Given this list of marker genes NFIB, G6PC3, ZFP62 (NCBI Gene Id 92379), TSPAN13, NECTIN4, TP53BP1, ENO3, FGD3, FAAP24, SCAMP2, ZNF658, FZD8, NIPA1, HDAC11, RAB2B, CRHBP, MED31, MRC2, PNPLA2, FRS3, RNF135, ENG, NCS1, MAP3K12, SERPINB9, AGPAT2, PDE4DIP, WDR75, AJUBA, MUL1, SPINDOC, SCNN1B, GLT8D2, EVL, SFTPC, POSTN, PPFIA4, PIGP, SERINC3, SSBP4, IRF2BPL, IRF3, BTG3, UBALD1, METTL22, CCDC122, DENND6B, TMEM144, PIP4K2C, MYBPC3, GCNT1, CALML4, SMPD1, CLPP (caseinolytic mitochondrial matrix peptidase proteolytic subunit), TP53I11, CAMTA2, FUBP3, GKAP1 (G kinase anchoring protein 1), MMS19, EPAS1, CLPTM1, JUP, SCN1B, RLIM, TBC1D9, SLC23A2, FAM234B, PPP1R10 (protein phosphatase 1 regulatory subunit 10), MYRIP, NT5C3B, LAMP2, NDFIP2, MARCHF2, AUP1, SOAT2, MNT (MAX network transcriptional repressor), ENC1, KLHL25, ABHD14A, METTL18, MOB2, TICAM1, PAPSS1, NOXO1, HEXD, KCP, SESN1, HS6ST1, CMYA5, TM2D1, ZNF141, ZEB1, SLC36A2, ARHGEF40, BANK1, DAGLB, ELAVL4, TTYH1, CEP68, NMD3, ZNF862, MYO7A, GBA1, RWDD3, CNNM2, TNFRSF11A, PLAAT3, NAA80, GNPTG (N-acetylglucosamine-1-phosphate transferase subunit gamma), ZNF32, HMOX2, ALDH7A1, ZNF777, TXNRD3, EXOG, RS1, GADL1, ZFYVE1, LONRF3, CNP, HERC2, SUSD3, ACTL7A, MYMK (myomaker, myoblast fusion factor), XPO5, FLRT1, PPM1E, COMMD9, CNPY3, OAF, TMED5, PLEKHO1 (pleckstrin homology domain containing O1), C19orf44, ITPKB, CAND2, DYNLT3, PRAF2, SH2B2, ATP6V0C, TMBIM1, PTBP1, C1orf122, CD22, TTC39B, IQSEC2, ITGB3BP, IDUA, PORCN (porcupine O-acyltransferase), C4B, PECR, ZNF354C, SETD2, SGSM3, VIPR1, EPS8L1, DNMBP, NDRG2 (NCBI Gene Id 57447), VWF, TGIF1, ZNF35 (NCBI Gene Id 7584), SLC25A23, IFT172, LAP3, NFKBIB, LTF, MYO1E, SRGAP3, GLB1, ZFP37, PIP4P1, GLMP, ADGRL2, CDK20, SSTR5, GLT8D1, TMEM50A, P2RX7, EEFSEC, EMC3, TEX35, GSTM3, HGH1, TPRKB, TJP2, B4GALT3, WBP2, CCT3, PPM1F, PDF, COMP, VAT1L, SMIM1, TMED4, PTPMT1, C11orf54, UBE2I, CEP85, CXCL16, KIF21B, DDA1, here is a description of the gene set: from publication Kerkar SP, Goldszmid RS, Muranski P, Chinnasamy D, Yu Z, Reger RN, Leonardi AJ, Morgan RA, Wang E, Marincola FM, Trinchieri G, Rosenberg SA, Restifo NP (PMID 22056381) Human Gene Set: GSE29164_UNTREATED_VS_CD8_TCELL_AND_IL12_TREATED_MELANOMA_DAY3_UP species: Homo sapiens Genes up-regulated in B16 melanoma (day 3): untreated versus mock treatment during adoptive transfer therapy. Myeloid-derived cells comprising the tumor stroma represent a heterogeneous population of cells critical to the structure, function and growth of established cancers. We have recently found that engineering tumor-specific CD8+ T cells to secrete IL-12 (IL-12TD) can lead to striking improvements in T-cell activity against established melanomas in murine models. Surprisingly, IL-12-dependent enhancement of CD8+ T-cell anti-tumor function did not occur through direct ligation of receptors on lymphocytes or NK cells. Instead, IL-12 sensitized host bone marrow-derived tumor-stromal cells, partly through interferon-gamma, to indirectly enhance the effects of adoptively-transferred T cells. Direct presentation of antigen by tumor was not necessary, but MHC class I expression on endogenous cells was essential for IL-12 mediated anti-tumor enhancements. Upon successful treatment with IL-12TD cells, we observed the selective elimination of tumor-infiltrating CD11b+ F4/80+ macrophages, CD11b+/ClassII+/CD11c+ dendritic cells and CD11b+/Ly6C+/Ly6G- but not CD11b+/Ly6C+/Ly6G+ myeloid-derived suppressor cells within regressing lesions. These results are consistent with a model whereby IL-12 triggers the maturation of myeloid-derived cells into competent antigen cross-presenting cells. Licensed recognition of these antigens by effector T cells may in turn trigger the collapse of the tumor stroma and aid in the regression of large vascularized lesions.